Given this list of marker genes ID3, BCL2L13, RIGI, SP110, LAMP3 (lysosomal associated membrane protein 3), TMEM97, TRIM22, OAS1, TRANK1, ISG15, ST8SIA4, OAS2, HSPA6, IFI27, USP18, HERC6, PDK4, HSPA1A, STAT1, LAP3, DNAJB4, OAS3 (NCBI Gene Id 4940), TNFSF10, HERC5, PRP4K, TLR3, OASL, TDRD7, PGRMC2, IFIH1, IFI44, ATP5MJ, HEXIM1 (NCBI Gene Id 10614), IFIT1, GRB14, HPGD, IRF7, DDX60, IFITM1, PARP12, SAMD9, TRIM5, MX1, IFI35, HSPA1B, TRIM14, IFIT3, AQP3, here is a description of the gene set: Top genes down-regulated in A549 cells (lung cancer) expressing STAT3 off an adenovirus vector. Human Gene Set: DAUER_STAT3_TARGETS_DN from publication Dauer DJ, Ferraro B, Song L, Yu B, Mora L, Buettner R, Enkemann S, Jove R, Haura EB (PMID 15735721) Wound healing and cancer are both characterized by cell proliferation, remodeling of extracellular matrix, cell invasion and migration, new blood vessel formation, and modulation of blood coagulation. The mechanisms that link wound healing and cancer are poorly understood. We report here that Stat3, a common signaling mechanism involved in oncogenesis and tissue injury, regulates a common set of genes involved in wound healing and cancer. Using oligonucleotide gene arrays and quantitative real-time PCR, we evaluated changes in global gene expression resulting from expression of Stat3 in lung epithelial cells. We report here previously uncharacterized genes induced by Stat3 implicated in signaling pathways common to both wound healing and cancer including cell invasion and migration, angiogenesis, modulation of coagulation, and repression of interferon-inducible genes. Consistent with these results, we found increased Stat3 activity associated with wound healing in chronically inflamed mouse lungs and increased Stat3 activity was identified at the leading edge of lung tumors invading adjacent nontumor stroma. These findings provide a molecular basis for understanding cancer as a deregulation of normal wound healing processes. studied in species Homo sapiens